The following is a description of a gene set: Any process that modulates the frequency, rate or extent of myeloid dendritic cell chemotaxis. species: Mus musculus Mouse Gene Set: GOBP_REGULATION_OF_MYELOID_DENDRITIC_CELL_CHEMOTAXIS, and this is the list of marker genes: Ccl21a, Ccl21d, Ccl21b, Ccl21f, Ccl21e, Spi1